The following is a description of a gene set: Oxidative phosphorylation (COX and ATPases). Human Gene Set: MODULE_307 studied in species Homo sapiens, and this is the list of marker genes: UQCRC2, ATP6AP1, COX5A, ATP6V1E1, UQCRC1, ATP6V1F, COX4I1, COX8A, COX7B, COX7C, SURF1, COX7A2, ATP6V0B, ATP6V1B2, COX6B1, UQCRFS1, COX5B, ATP6V1C1, COX6A1, COX6C, COX7A1, UQCRB, UQCR11, ATP1B1, ATP6V0C